Given this list of marker genes TRAPPC3, MKNK2, PNISR, CPD, ETS1, KANSL1, here is a description of the gene set: from publication Chen Y, Wang X (PMID 31504780) Human Gene Set: MIR1180_3P Genes predicted to be targets of miRBase v22 microRNA hsa-miR-1180-3p in miRDB v6.0 with MirTarget v4 prediction scores > 80 (high confidence targets). studied in species Homo sapiens